Given this list of marker genes MERTK, CYP19A1, BAK1, TBX3, RBP4, CHD7, WNT5A, SRD5A1, NPR2, BAX, STRA6, ESR1, FGF10, LHX1, SRD5A2, AXL, LRP2, TP63, TYRO3, here is a description of the gene set: studied in species Homo sapiens Human Gene Set: GOBP_FEMALE_GENITALIA_DEVELOPMENT The process whose specific outcome is the progression of the female genitalia over time, from formation to the mature structure.